The following is a description of a gene set: The region of a chromosome that includes the centromeric DNA and associated proteins. In monocentric chromosomes, this region corresponds to a single area of the chromosome, whereas in holocentric chromosomes, it is evenly distributed along the chromosome. Human Gene Set: GOCC_CHROMOSOME_CENTROMERIC_REGION species: Homo sapiens, and this is the list of marker genes: LRWD1, SMARCA4, SKA2, KAT2B, NSL1, PMF1, CENPV, KIF2C, MIS18BP1, CHMP4C, CENPX (centromere protein X), CHMP2B, CHMP7 (charged multivesicular body protein 7), CENPK, HSF1, CENPI, MACROH2A1, NSMCE1, KDM4C, SEH1L, NUP107, SYCP3, MIS18A, NUP133, BIRC5, DAPK3, KIF2B, SMC6, SGO1, C9orf78, AURKB, SIN3A, SS18L1, SYCP2L, SPDL1, SMARCC2, NEK2, ARID2, ATRX, H2AC8, CSNK1A1, AHCTF1, HJURP, CHMP5, LUZP1 (NCBI Gene Id 7798), SPOUT1, SMARCD2, CBX5, PKHD1, POLE3 (DNA polymerase epsilon 3, accessory subunit), ZNF330, NCAPG, ANAPC16, CLASP1, NDE1, CHMP4A, CENPO, XPO1, KNL1, ACTL6A, MTCL1, TPR, SMC1A, HELLS, ITGB3BP, RANGAP1, CDC20, PPP1R12A, CHMP3, NDEL1, CENPQ, NCAPD2, CCNB1, DYNLL1, SMARCE1, ZNF207, CHMP4BP1, REC8, CHMP2A, RASSF2, CHMP4B, H4C3, WAPL, SMARCC1, PSEN1, TP53BP1, SKA3, FLYWCH1, KDM4D, PHF2, CBX3, UHRF2, KANSL1, TEX14, GPATCH11, PINX1, H4C6, PPP1CC, FIRRM, MEAF6, SMC1B, H4C4, SEPTIN2, NGDN, DYNC1LI1, CENPN, TTK, BUB1B, DCTN1, ZW10, BOD1L2, MAD2L1, STAG3, SMARCD1, ESCO2, DAXX (NCBI Gene Id 1616), TOP2A (DNA topoisomerase II alpha), SPC24, DNMT1, KNTC1, CEBPB, MAD1L1, SEC13 (SEC13 homolog, nuclear pore and COPII coat complex component), CENPF, MIS12 (MIS12 kinetochore complex component), SUV39H2, CDT1, H4C1, BUB3, PLK5, CENPA, DCTN2, STAG1, CHRAC1, DYNC1I1, NUP98, DSCC1, DCTN4, SEPTIN7 (septin 7), KAT8, SPAG5, RCC2, SMC4, SMARCA5, PLK2, H3-3A, FBXW11, PSEN2, PPP2CA, PLK1, ZWILCH, IKZF1, CDCA8, ZWINT, CFDP1, CENPE, CLIP1, PHF10, H4C15 (H4 clustered histone 15), SGO2 (NCBI Gene Id 151246), KNSTRN, CENPP, CENPU, H4C12, BRD7, PAFAH1B1, CTCF, CLASP2, NUP85, PLK3, CDCA5, H4C14, EZH2, NUP43, SEPTIN6, CENPM, CENPW, NUP37, NCAPD3, H4C11, CENPL, SUV39H1, ORC2, ERCC6L2, PDS5A, BAZ1B, SYCP2, PPP2CB, DYNC1LI2, H4C9, PPP2R5C, KMT5C (lysine methyltransferase 5C), SPC25, KIF18A, ERCC6L, PBRM1, NDC80, PRP4K, AURKC, STAG2, H2BC11, CHAMP1, CBX1, ZNF276, SMC5, CHMP1B, KAT7, MEIKIN, RAD21, CENPB, DYNLT3, GTF2B, CENPT, CENPS, NUP160, CKAP5, FBXO28, SYCP1, BAZ1A, CENPC, TRAPPC12, PDS5B, KIF22, H4C8, DCTN6, ACTB, BOD1, OIP5, UVRAG, SIRT6, NUF2, DNMT3A, FMR1, PPP2R1A, SMARCB1, PHF6, APC, ZNF618, SUGT1, H4C5, H3-3B, H4C13, DCTN5, MTBP, SUMO3, HNRNPU, CENPH (NCBI Gene Id 64946), DCTN3, KDM4A, KMT5B, SMC3 (structural maintenance of chromosomes 3), INCENP, H2AC4, ACTL6B (actin like 6B), DSN1, KAT5, H4C2, NUDCD2, CHMP6, CHMP1A, SNAI1, AURKA, BUB1, PPP2R5A, H4C16, SKA1